The following is a description of a gene set: species: Mus musculus Mouse Gene Set: GOCC_PROXIMAL_NEURON_PROJECTION The portion of an axon or dendrite that is close to the neuronal cell body., and this is the list of marker genes: Syt5, Gjc2, Map2, Trim46, Ptger3